The following is a description of a gene set: Mouse Gene Set: GOBP_POSITIVE_REGULATION_OF_MAPKKK_CASCADE_BY_FIBROBLAST_GROWTH_FACTOR_RECEPTOR_SIGNALING_PATHWAY The series of molecular signals generated as a consequence of a fibroblast growth factor receptor binding to one of its physiological ligands resulting in an increase in the rate or frequency of a MAPKKK cascade. studied in species Mus musculus, and this is the list of marker genes: Fgfr3, Fgf21, Fgf23, Klb, Kl, Fgfr1